Given this list of marker genes Crot, Acaa1b, Hsd17b4 (hydroxysteroid (17-beta) dehydrogenase 4), Ehhadh (enoyl-Coenzyme A, hydratase/3-hydroxyacyl Coenzyme A dehydrogenase), Acbd4, Decr2, Hao2, Acox3, Amacr, Acox2, Nudt19, Pecr, Acox1, Acbd5 (NCBI Gene Id 74159), Abcd1, Scp2, Acot4, Slc25a17, Slc27a2, Eci2, Hacl1, Crat, Aldh3a2, Acot8, Acoxl, Mlycd, Phyh, here is a description of the gene set: Mouse Gene Set: REACTOME_PEROXISOMAL_LIPID_METABOLISM species: Mus musculus Peroxisomal lipid metabolism